Given this list of marker genes DVL1, SNAPIN, SYT4, RAP1BL, LRRK2, BRAF (B-Raf proto-oncogene, serine/threonine kinase), SYT8, ERC2, GPR151, CADPS, PIP5K1C, PRKCG, STX1B (NCBI Gene Id 6805), RAP1B, WNT7A (Wnt family member 7A), BRSK1, SYT9, PPP3CA, CACNB4, CADPS2, CDK5, STX11, NLGN1, CALM3, SYNGR3, SYNJ1, FBXO45, SEPTIN5, NAPA, CPLX3, SNAP23, RIMS4, P2RX7, P2RY1, TPRG1L, PSEN1, PPFIA2, CPLX4, DOC2A, NAPB, CACNA1B, FBXL20, SYT11, SYT12 (NCBI Gene Id 91683), STXBP5, SYP, RAB3GAP1, PRRT2, SYT1, RPH3A, PREPL, SYT7, STXBP1, ATP2A2, DNAJC5, SLC4A8, RIMS2, OTOF, PCLO, UNC13C, BLOC1S6, RAB5A, GIT1, SNAP47, VPS18, STXBP3, STXBP2, SNAP25, RIMS1, STX19, RPH3AL, SNAP29, OSBPL2, GRIK5, SYT13, SCRIB, SNCA, SYN1, SV2A, SNPH, SV2C, SYT10, RAP1A, CPLX2, CPLX1, UNC13A, EFR3A, NPY, CASK, VAMP2, DOC2B, PRKCB, UNC13B, RAB3A, SV2B, SYT5, SYT2, RIMS3, FMR1, STX1A, PPFIA3, STX2 (syntaxin 2), CSPG5, PFN2, DTNBP1, P2RX1, here is a description of the gene set: Fusion of intracellular membrane-bounded vesicles with the pre-synaptic membrane of the neuronal cell resulting in release of neurotransmitter into the synaptic cleft. Human Gene Set: GOBP_SYNAPTIC_VESICLE_EXOCYTOSIS species: Homo sapiens